The following is a description of a gene set: IFN-gamma transcriptional responses in control and IFN-gamma primed primary human macrophages Genes up-regulated in macrophages: untreated versus stimulated by IFNG for 3h. Human Gene Set: GSE1925_CTRL_VS_3H_IFNG_STIM_MACROPHAGE_UP from publication Hu X, Park-Min KH, Ho HH, Ivashkiv LB (PMID 16148108) species: Homo sapiens, and this is the list of marker genes: CSNK2A2, B3GALT2, SLC9A8, CRTAP, NOP16, EXTL3, STAT5B, TYROBP, FURIN, CHL1, COPS7A, SLC35C2, SEMA4F, GLG1, HDDC2, PDCD1, GJA1, SPECC1, RPL7L1, EIF4EBP1, IRF4, RECQL5, CMIP, NFATC1, CARS1, LMO2, CNPY2, CD2, AHCYL1, G6PD, MOV10, MRPL35, BATF, TSC2, PLGRKT, FASLG, CD5, HK2, SLC25A25, C1QA, CRTAM, FAM162A, EXT1, YBX1, NAB2, NFKB2, AIMP2, PABPC4, HK1, ODC1, LCP1, DNAJC2, SDHAF1, SUPV3L1, IPO4, TNFRSF4, EIF4A1, PRKDC, LTA, TERF2, RPL22L1, LGALS3, REX1BD, SRM, ATP5F1E, CNN2, CD82 (NCBI Gene Id 8052), PTPN13, SFXN1, ROMO1, NPEPL1, JARID2, ECE1, MRPL45, PPAN, COMT, MAPKAPK2, CD6, RPN2, METTL1, EPHX1, ACAD9, TNNI3, RPLP1, DNAJC3, NME1, TAOK3, BCL2A1, PARP8, NDUFAB1, UQCRQ, TNNT1, TTL, ST6GALNAC4, BCL2L11, LEF1, LAP3, GPN1, ZFP1, TMEM70, RELB, SLC7A7, BCL2L13, RPS15A, GJA10, VKORC1, HEPH, GPD2, UTP14A, SH2D2A, RFC1, TFB2M, SUPT6H, BYSL, DIO1, NCOR2 (nuclear receptor corepressor 2), UBE2O, NIFK, GCSH (NCBI Gene Id 2653), TGM2, PPRC1, PACSIN1 (protein kinase C and casein kinase substrate in neurons 1), TNFSF11, BOP1, CLPB, MECR, DUSP2, DPYSL3, POLR1B, SNX14, IER2, KLK8, CD320, AGPAT3, SURF2, MARS1, GUK1, SLC5A6, CERS2, CAVIN3, P2RX4, SNORA7A, LONP2, TYRO3, MSRB1, DUSP1, PNO1, SLC19A1, STAT6, TESK1, ENPP1, ZSWIM7, UBXN8, POU5F1, MRPL36, RPS27 (ribosomal protein S27), PEPD, LETM1, CD72 (CD72 molecule), ANXA1 (NCBI Gene Id 301), FPGS, GEMIN5, NUCB2, GART, NR4A1, DNMT3A, SMYD5, PIK3C3, B4GALNT1, REXO5, C8orf82, PARM1, ASAP1, C1QC, CCL2, TIMM9, TNFRSF1B (TNF receptor superfamily member 1B), MTOR, SEPSECS, ITM2A, RSPH3, ZNF148, SOX4, AQR, AGO2, RARS2, MIOS, PAPOLA (poly(A) polymerase alpha), STAT5A, VARS1, USP4, ST7, UBXN4, MRPL17 (NCBI Gene Id 64996), SEC16A, NNAT, DDB1, UQCC2, SERF1A, VCP